Given this list of marker genes Rps27a, Epas1, Vhl, Hif3a, Psma6, Psma1, Psma7 (proteasome subunit alpha 7), Ubb, Psma4, Psmb4, Psmd12, Hif1a, Psma2, Psmb6, Psmd6, Psmc3, Psmc5, Psmc4, Psmd1, Ube2d1, Psmc6, Psmd13, Psma3, Psmd7, Psmc1, Psmb7, Psmc2, Ajuba, Psma5, Psmb5, here is a description of the gene set: electronically inferred by orthology from the curated human pathway part of: Cellular response to hypoxia species: Mus musculus This event has been computationally inferred from an event that has been demonstrated in another species.<p>The inference is based on the homology mapping from PANTHER. Briefly, reactions for which all involved PhysicalEntities (in input, output and catalyst) have a mapped orthologue/paralogue (for complexes at least 75% of components must have a mapping) are inferred to the other species. Reactome Pathway: Oxygen-dependent proline hydroxylation of Hypoxia-inducible Factor Alpha